The following is a description of a gene set: Mouse Gene Set: GOBP_PROTEIN_AUTOUBIQUITINATION species: Mus musculus The ubiquitination by a protein of one or more of its own amino acid residues, or residues on an identical protein. Ubiquitination occurs on the lysine residue by formation of an isopeptide crosslink., and this is the list of marker genes: Rnf122, Ercc8, Rag1, Klhl24, Rnf181, Rnf4, Sh3rf1, Traf2, Rnf185, Rad18, Asb4, Rbx1-ps (NCBI Gene Id 100046417), Sash1, Dtx3l, Sh3rf3, Rnf141, Cul3, Ltn1, Sh3rf2, Ube4b, Trim68, Rchy1, Mta1, Rnf8, Marchf5, Ube2t, Rnf183, Lrsam1, Rnf19b, Stub1, Marchf7, Cbl, Rnf220, Trim11, Ube2d2a, Itch, Trim71, Trim37, Rnf112, Obi1, Trim30a, Trim13, Traf6, Rnf10, Trim58, Trim17, Brca1 (NCBI Gene Id 12189), Ddb2, Uhrf2, Ube2b, Rnf13, Nfx1, Rnft1, Hectd1, Wwp2, Rbx1, Lrrk2, Uhrf1, Cnot4, Ube3a, Prkn, Bfar, Rnf11, Ube2d3, Rnf133, Rnf115, Rnf187, Rnf186, Ube3d, Trim21, Rnf146, Rnf208, Jade2, Mdm2, Trim52, Rnf213, Rnf41, Amfr